Given this list of marker genes Tnfrsf14, Tnfrsf4, Tnfsf11, Tnfsf15, Tnfrsf25, Lta, Tnfsf8, Tnfrsf1b, Tnfrsf18, Tnfrsf17, Tnfrsf1a, Eda, Tnfsf18, Tnfrsf11b, Cd70, Tnfsf9, Tnfsf13, Cd27, here is a description of the gene set: Reactome Pathway: TNFs bind their physiological receptors studied in species Mus musculus electronically inferred by orthology from the curated human pathway part of: TNFR2 non-canonical NF-kB pathway This event has been computationally inferred from an event that has been demonstrated in another species.<p>The inference is based on the homology mapping from PANTHER. Briefly, reactions for which all involved PhysicalEntities (in input, output and catalyst) have a mapped orthologue/paralogue (for complexes at least 75% of components must have a mapping) are inferred to the other species.